Given this list of marker genes NPPB, GUCY2C, NPPA, GUCY1B1, NPR2, NPPC, GUCY2F, GUCY1A2, GUCY1A1, GUCY2D, NPR1, here is a description of the gene set: The chemical reactions and pathways resulting in the formation of cyclic GMP, guanosine 3',5'-phosphate. Human Gene Set: GOBP_CGMP_BIOSYNTHETIC_PROCESS studied in species Homo sapiens